Given this list of marker genes BRD8 (bromodomain containing 8), DIAPH1, RNF44, XRCC5, NCL, SAFB, ARPC2, CAPZA1, WDR1, CTBP1, API5, RHOA, PPIE (NCBI Gene Id 10450), DGKD, RXRB, LSM14A, DNAJC8, SNW1, ATF4, ZFC3H1, PSMA1, NACA, SUMO2, RPL22, SLC25A6, RBM5, TACC1, EIF4G2, ZBED1 (NCBI Gene Id 9189), ADD1, PTP4A2, HNRNPK, RABGGTB, RNPS1, ZFPL1, KXD1, CSK, DDX49, SUGP2, SRF, U2AF1, UBE2I, ACP1, CNPPD1, EIF3D, HNRNPUL1, NXF1, SNRNP70, DHX38, ANAPC5, HNRNPD, SRP14 (NCBI Gene Id 6727), EFCAB14 (NCBI Gene Id 9813), DDX39B, EIF4A2 (eukaryotic translation initiation factor 4A2), PHIP, DDX17, FAM168B, PRPF8, SRSF2, ZNF337, PTBP1, here is a description of the gene set: Neighborhood of SNRP70 studied in species Homo sapiens Human Gene Set: MORF_SNRP70 Neighborhood of SNRP70 small nuclear ribonucleoprotein 70kDa polypeptide (RNP antigen) in the MORF expression compendium